Given this list of marker genes SLC37A4, MST1, PLCG2, NOD2, WAS, MASP2, BACH2, CARD11, IL37, MAP3K7, IL6, DOCK11, CYBC1, TCF4, INAVA, SEMA4D, GPR35, here is a description of the gene set: A chronic inflammatory bowel disease that includes characteristic ulcers, or open sores, in the colon. The main symptom of active disease is usually constant diarrhea mixed with blood, of gradual onset and intermittent periods of exacerbated symptoms contrasting with periods that are relatively symptom-free. In contrast to Crohn's disease this special form of colitis begins in the distal parts of the rectum, spreads continually upwards and affects only mucose and submucose tissue of the colon. Human Gene Set: HP_ULCERATIVE_COLITIS Ulcerative colitis species: Homo sapiens